The following is a description of a gene set: species: Homo sapiens Human Gene Set: GOBP_ENDODERMAL_CELL_FATE_COMMITMENT The cell differentiation process that results in commitment of a cell to become part of the endoderm., and this is the list of marker genes: CDC73, GATA6, EOMES, POU5F1, DKK1, NANOG, MESP1, RTF1, CTR9, HNF1B, CTNNB1, LEO1, PAF1 (NCBI Gene Id 54623), SOX2, SOX17